Given this list of marker genes TSC22D1, SLAIN2, PPHLN1, LYST, PLEKHM3, ALDH9A1, VPS33B, MROH1, ZIC5, ELK4, TCP11, ZMIZ1, RFX3, SLC4A7, HSD17B4, CDC42SE1, NAPB, FRMD8 (FERM domain containing 8), MTFP1, HADH, RNF166, AGFG2 (ArfGAP with FG repeats 2), FAM120A, INSR, APPL2, BBS9, CLIP1, SH3GLB2, PECAM1, TRMT6, BACE2, MORF4L1, PPP3CA, MAN1C1, PPP2R5A, LAIR1, TBC1D4, POGLUT2, RNPC3, SYK, LYPLA1, COQ10A, SLC16A5, DOCK5, WDR26, CAAP1, ZNF546, IQCE, ITGA4, TRIM23, MXRA7, PTGR3, CRIP1, CAPNS2, ERI2, COG6, CELF1, PTGR2, AACS, RIPOR2 (RHO family interacting cell polarization regulator 2), FCN1, PLEKHA6, ARGLU1, SBK1, DDX46, NDRG1, HPGD, CALHM2, RAB4A, DAP, MEGF9, AGA, IFI27, PHF7, CFAP95, AVPR2, APPBP2, ENC1, ACOXL, LCA5, PGAP1, MEX3B, CD72, VAT1, TENT5A, ADGRG3, CSRNP2, CBLL1, CITED2, CRACDL, PGP, TAF5L, TMEM135, AS3MT, FUT8, VSIR, FAM199X, LIMS4, MAPK10 (mitogen-activated protein kinase 10), THEM5, TPO, RECQL, PHKG1, HEY2, CCPG1, ST8SIA4, NRG3, CERS5, PHLDB2, NUAK1, KICS2, PRXL2A, FCER2, GSTM4, PDE4DIP, ARMC6, DDX3X, GSTO1, WDR11, CDIPT, RGMA, ADD1, FAM117B, GLB1L3, SLC25A35, TM7SF3, SGSH, FAM120C, MAP1LC3B, FAR1, POU2AF1, MANBA, SCRN3, NUDT4, DBP, ANKRD23 (ankyrin repeat domain 23), FAM98C, CCDC115, OXCT1, MFAP1, NFATC3, ZNF322, TEX10, BLOC1S5, MCUR1, CRIPTO, STX6, ZMYND11, DTX1, ERICH2, PDE8B, CNOT2, ACAA2 (NCBI Gene Id 147548), CACNA2D4, THAP12, WDR6, SQLE, CAPN2, EPHX1, PSEN2, PXYLP1, VPS37A, SCPEP1, ORAI2, SSX2IP, RBMX, THOC2, MICU3, CAT, VIPR1, ATP2B1, OTUD7A, RTN4RL1, ARHGEF4, TBC1D13, FKBP7, CCDC162P, IRF2BPL, CIRBP, GBX2, VIM, ZFYVE21, SSTR4, CBFA2T2, UBTFL1, KIZ, GALNT9, GOLT1A (golgi transport 1A), ZNF205, BBOF1, CCDC17, KCNK10 (potassium two pore domain channel subfamily K member 10), MKRN2, LYPD6B, RNF138, LRRC23, QPRT, DCK, PTPRN, here is a description of the gene set: species: Homo sapiens To obtain insight into the genetic basis of the increase of functional activity of memory B cells over time, we compared the gene expression profiles of day 7 and day 40 NP-specific/IgG1 memory B cells, GC B cells and plasma cells in immunized WT mice and naïve B cells, before and after activation in vitro. Genes down-regulated in day 7 memory B cells versus day 40 germinal center B cells. from publication Kaji T, Ishige A, Hikida M, Taka J, Hijikata A, Kubo M, Nagashima T, Takahashi Y, Kurosaki T, Okada M, Ohara O, Rajewsky K, Takemori T (PMID 23027924) Human Gene Set: GSE11961_MEMORY_BCELL_DAY7_VS_GERMINAL_CENTER_BCELL_DAY40_DN